The following is a description of a gene set: Genes positively differentially expressed in cell type: cDC2 (conventional dendritic cell type 2) upon treatment with cytokine: RANKL in mouse lymph nodes in vivo. Cytokines mediate cell-cell communication in the immune system and represent important therapeutic targets. A myriad of studies have highlighted their central role in immune function, yet we lack a global view of the cellular responses of each immune cell type to each cytokine. To address this gap, the authors created the Immune Dictionary, a compendium of single-cell transcriptomic profiles of more than 17 immune cell types in response to each of 86 cytokines (>1,400 cytokine-cell type combinations) in mouse lymph nodes in vivo. A cytokine-centric view of the dictionary revealed that most cytokines induce highly cell-type-specific responses. For example, the inflammatory cytokine interleukin-1β induces distinct gene programmes in almost every cell type. A cell-type-centric view of the dictionary identified more than 66 cytokine-driven cellular polarization states across immune cell types, including previously uncharacterized states such as an interleukin-18-induced polyfunctional natural killer cell state. species: Mus musculus Mouse Gene Set: CUI_CDC2_RANKL_RESPONSE_UP from publication Cui A, Huang T, Li S, Ma A, Pérez JL, Sander C, Keskin DB, Wu CJ, Fraenkel E, Hacohen N (PMID 38057668), and this is the list of marker genes: Ptpre, Chd8, Rsbn1, Nfam1, Cd244a, Selenos, Cep164